The following is a description of a gene set: from publication Pongubala JM, Northrup DL, Lancki DW, Medina KL, Treiber T, Bertolino E, Thomas M, Grosschedl R, Allman D, Singh H (PMID 18176567) species: Homo sapiens Genes up-regulated in pro-B cells with PAX5 knockout: control versus over-expressing EBF1. Human Gene Set: GSE9878_CTRL_VS_EBF_TRANSDUCED_PAX5_KO_PRO_BCELL_UP We have determined that sustained expression of EBF suppresses alternate lineage genes independently of Pax5., and this is the list of marker genes: SEPTIN9, CLDN12, CNN2, CREG1, ARHGEF4, ALYREF, ABHD14B, QRICH1, CA2, HPN, MS4A7, EMB (NCBI Gene Id 133418), CCL4, SELENON, HAGHL, NR2E1, NHSL3, BRWD1, ETV6, ZNF653, ISLR, TIE1, MAP1LC3A, METTL3, TTC39B, ADIPOR2, RBFOX3, CCNL1, GLRX, SVIP, MAGED1 (MAGE family member D1), EVI2B, NHLRC3, HSD3B2, VCP, FCGRT, ZBTB17, GRAMD1A, CCDC157, SERTAD2, SUSD6, GJA10, PDZK1IP1, ART1, APOBR, PLEC, ADPRHL1 (NCBI Gene Id 400169), PDGFRB, JPH1, TNS1, XKR5, IFFO2, SGSH, SSRP1, TMEM150A, RNASE6, KLF9, GPX3, TAP2, ABCG8, RNF130, CCDC115, SMC1B, TMEM176A, HLA-C, EYA2, SMAD7, DOCK1, ANXA2, HSPA12B, RHOF, ITPRIP, RHBDL3, FGF3, DENND1C, MIB2 (MIB E3 ubiquitin protein ligase 2), FAM163A, CIC, RIMBP2, EGR1, DUSP1, GLT6D1, ENG, AKNAD1 (NCBI Gene Id 254268), SLC35C2, LDB1, GUCY2C, SRXN1, PGGHG, CSNK1E, DAGLB, DOCK6 (dedicator of cytokinesis 6), VILL, UCKL1, GLIS2, C9, ITGA6, GLB1, GSTO1, NFIC, CD96, WDR13, USB1, INS, CRYZL1, IL1R1, TEX264 (NCBI Gene Id 51368), PLSCR1, FAM110C, RNF217, GSR, TNNI3, GALNT6, DAG1, MATK, DENND2D, ACOX1, DTNBP1, JPH3, GSTM3, GAK, GYS1, IFRD2, EIF3A, LCP1, RYK, PKN1, MBOAT7, PAFAH2, PPP4R4, HS1BP3, SIRT2, PRR12, FGFBP3, KANSL3, ECE1, SPNS3, PTGER3, ELAC1, BAMBI, APOE, RGMB, COL6A2, F2, INSM2, ADAM15, MXD1, PELI2, SELENOP, GOLM1, SLC35C1, LIME1, GSTM2, TRIO, KRT28, FLYWCH2, MYO1D, NAGA, OGFRL1, SLC25A24, EMP3, SYCP1, COPZ2, CLEC4E, GPR17, ZFPM1, SYT11, PDLIM7, MCEE, ACTN4, HEXA, GKAP1, MYOF, ECI2, NBEAL2 (NCBI Gene Id 23218), PROX2, TMEM88, VSNL1, TTLL3, DEF8, CTSD, F2R, IFT57, HEPHL1, GPR75, FLNC, G6PC2, TUBA8, TBXAS1, CTBP2, APPL2 (NCBI Gene Id 55198), SORBS3, ABHD5, KRTAP15-1, ESRRG, TGM2, FRMD5, ZKSCAN5, ETFB, PTN